Given this list of marker genes RXFP1, CAV1, VDR, NFKB1, TGFBR2, GLI3, STAT6, ELF3, TFAP2C (NCBI Gene Id 7022), WNT5A, NRG3, AR, FGF10, CSF1R, BMP4, SCRIB, CAPN1, MED1, CCL11 (C-C motif chemokine ligand 11), CSF1, MSX2, ETV5, FGFR2, KDM5B, TGFB1, BAX, BSX, PERP, CAV3, CDKN2A, ESR1, TBX2, PGR, NR3C1, AREG, DDR1, WNT4, PHB2, CSMD1 (CUB and Sushi multiple domains 1), PML, IGFBP5, PTCH1, EPHA2, TBX3, LRP5, SRC, NTN1, SOSTDC1, BTRC, here is a description of the gene set: The process in which anatomical structures of the mammary gland are generated and organized. Morphogenesis refers to the creation of shape. The mammary gland is a large compound sebaceous gland that in female mammals is modified to secrete milk. species: Homo sapiens Human Gene Set: GOBP_MAMMARY_GLAND_MORPHOGENESIS